Given this list of marker genes FHL1, RNF144A, IPCEF1, FYB1, ZAP70, CCND2, TNFSF14, S100A4, PDE4D (NCBI Gene Id 654081), CCR2, TRPV2, PHACTR2 (phosphatase and actin regulator 2), ITK, TNFSF10, KLRB1, SLC39A8, TNFAIP3, IFITM1, SKAP1, BLMH, GATA3 (GATA binding protein 3), IL11RA, AQP3, TIAM1, LEPROTL1, PDE3B, STAT4 (signal transducer and activator of transcription 4), CCSER2, TBC1D4, DEXI, CD6, CD247, RIC8B, MICAL2, TTLL1, TMEM30B, APBA2, CPD, PTPN13, TRAT1, RUNX1, GNAQ, PRKCQ (protein kinase C theta), SVIL, VIM, WWP1, CDR2, DNMT1, PIM1, ZNF277, KLRG1, RCAN3, TMEM123, IGF2R, TNFSF8 (NCBI Gene Id 944), AK5, ARRB1, FKBP5, GPD1L, SRGN, SELPLG, TOB1, RASGRP1, LEF1, ATP1A1, LDLRAP1, SH2D2A, SH2D1A (SH2 domain containing 1A), SFI1, GIMAP5 (NCBI Gene Id 55340), IL10RA, CAMK2G, PRKCH, FYN, CYLD, ZMYM6, CORO2A, ITM2A, IL2RB, LCK, PIK3IP1, FBXL8, CLUAP1, AP3M2, SPATS2L, SEMA4D, CCND3, BCL11B, PRORP, GZMK, WDR82, LPAR6, TGFBR3, ICOS, TARP, RGS10, UPP1, MGAT4A, CCR5, TIMP1 (TIMP metallopeptidase inhibitor 1), CYB561, LGALS8, PRMT2, BEX3, GIMAP4, TKTL1, TMEM43, STAT5B, CISH, ITGA6, NHERF1, TRBV10-2, GSTK1, ARL4C, PLAAT4, P2RX4, PRDX2, PLCG1, VAMP5, DPP4, PRKACB (NCBI Gene Id 5567), TNFRSF25, LDHB, VPS26C, TRBC1, RPS6KA3 (NCBI Gene Id 6197), SERINC5, HPGD, DUSP7, ATP2B4, SOCS2, STOM, DYRK2, UBASH3A, RORA, DOCK9, MT1F, SAMHD1 (SAM and HD domain containing deoxynucleoside triphosphate triphosphohydrolase 1), RAB33A, PRF1, PLK3, TXK, PIP4K2A, INPP4A (inositol polyphosphate-4-phosphatase type I A), PRKCA, CERK, ATP10A (NCBI Gene Id 57194), MAL, PTPN4, SEMA4C, PXN, NCALD, DPYD, BMAL1, ITPKB, FLT3LG, BNIP3 (NCBI Gene Id 664), CD2, MAF, TBC1D2B, CD28, URI1, OPTN, STXBP1, ATP6V0E2, AAK1, C1orf216, PLIN2, LINC00623, MLLT3, PIK3R1, MYBL1, HDAC4, TNIK (TRAF2 and NCK interacting kinase), EEIG1, ACVR1, RGCC, LRIG1, PLCL1, MT1X, GOLGA7, PTGER2, CCL5, SIRPG, GZMA, ID2, CD3G (NCBI Gene Id 917), TRAV8-3, GIMAP6, LIMA1, WDR1, NOSIP, ANXA1, TRDV2, AKTIP, NELL2, NACC2, CHST7, CALM1, here is a description of the gene set: from publication Hutcheson J, Scatizzi JC, Siddiqui AM, Haines GK 3rd, Wu T, Li QZ, Davis LS, Mohan C, Perlman H (PMID 18275831) Human Gene Set: GSE10325_CD4_TCELL_VS_BCELL_UP studied in species Homo sapiens Genes up-regulated in comparison of healthy CD4 T cells versus healthy CD19 B cells. Gene expression profile studies have identified an interferon signature in whole blood or mononuclear cell samples from patients with systemic lupus erythematosus. This study was designed to determine whether specific lymphocyte and myeloid subsets freshly isolated from the blood of systemic lupus erythematosus patients demonstrated unique gene expression profiles compared to subsets isolated from healthy controls.